The following is a description of a gene set: Human Gene Set: GOBP_PROTEIN_INSERTION_INTO_MEMBRANE The process that results in the incorporation of a protein into a biological membrane. Incorporation in this context means having some part or covalently attached group that is inserted into the the hydrophobic region of one or both bilayers. species: Homo sapiens, and this is the list of marker genes: EGFR, UBL4A, WNK1, COX18, EMC7, GRIN3B, NCLN, GET4, EMC10, SGTA, TMEM126A, EMC6, TMCO1, SEC61A1, CCDC47, EMC8, GET3, MOAP1, RAB5IF, TRAM1L1, EMC4, RTP2, EMC3, NOMO1, RTP1, BAX, EMC1, RTP5, BAG6, MAIP1, TRAM1, TMEM147 (transmembrane protein 147), RTP4, CAMLG (calcium modulating ligand), RTP3, REEP1, EMC2, TRAM2, BCS1L, WDR83OS (NCBI Gene Id 51398), NOMO2, OXA1L, EMC9, GET1, MAL, NOMO3, MMGT1